The following is a description of a gene set: Mouse Gene Set: GOBP_MESENCHYMAL_STEM_CELL_PROLIFERATION The multiplication or reproduction of mesenchymal stem cells, resulting in the expansion of a stem cell population. A mesenchymal stem cell, or MSC, is a cell that retains the ability to divide and proliferate throughout life to provide progenitor cells that can differentiate into specialized mesenchymal cells. studied in species Mus musculus, and this is the list of marker genes: Six2, Scrg1, Ltbp3, Ccne1, Vegfc, Tgfb1, Tgfbr1, Ndufs6, Fermt2 (fermitin family member 2), Bmp4